The following is a description of a gene set: Binding to a ferrous iron ion, Fe(II). Mouse Gene Set: GOMF_FERROUS_IRON_BINDING studied in species Mus musculus, and this is the list of marker genes: Fthl17f (NCBI Gene Id 434729), Th (tyrosine hydroxylase), Hif1an, Trf, Egln2, Ftdc2, Fthl17d, Phyh, Alkbh2, Fthl17c, Iscu, Plod1, Ftmt, Tet2, Acp5, Ftl1, Nt5e, Haao, Fthl17b, Fthl17a, Snca, Heph, Cdo1, Fxn, Alkbh1, Egln1, Ftl2-ps, Dph3, Ftdc1, Urod, Fth1, Alkbh3, Dnajc24, Fthl17e, Egln3, Fto